Given this list of marker genes Tacr1, Gper1, Lck, Tacr3, Abat, Oxtr, Tacr2, Oxt, Adra2b, here is a description of the gene set: studied in species Mus musculus Any process that increases the frequency, rate or extent of uterine smooth muscle contraction. Mouse Gene Set: GOBP_POSITIVE_REGULATION_OF_UTERINE_SMOOTH_MUSCLE_CONTRACTION